The following is a description of a gene set: species: Mus musculus Any process that results in a change in state or activity of a cell (in terms of movement, secretion, enzyme production, gene expression, etc.) as a result of a methionine stimulus. Mouse Gene Set: GOBP_CELLULAR_RESPONSE_TO_METHIONINE, and this is the list of marker genes: Mtor, Bmt2, Nfe2l2, Mat2a, Prmt1